Given this list of marker genes ARF4, GPLD1, PLD1, PLD3, ARL1, FAM83B, SNCA (NCBI Gene Id 6622), PLD4, PLD2, ENPP2, here is a description of the gene set: species: Homo sapiens Human Gene Set: GOMF_PHOSPHOLIPASE_D_ACTIVITY Catalysis of the reaction: a phosphatidylcholine + H2O = choline + a phosphatidate.